Given this list of marker genes Cxcl12, Wbp1l, Cxcr4, Entrep1, Trem2, here is a description of the gene set: The series of molecular signals initiated by the binding of the C-X-C chemokine CXCL12 to a C-X-C chemokine type 4 receptor (CXCR4) on the surface of a target cell, and ending with the regulation of a downstream cellular process, e.g. transcription. Mouse Gene Set: GOBP_CXCL12_ACTIVATED_CXCR4_SIGNALING_PATHWAY studied in species Mus musculus